Given this list of marker genes Snx18, Rhoa, Spire1, Snx9, Snx33, Spire2, Aurkb, here is a description of the gene set: Mouse Gene Set: GOBP_CLEAVAGE_FURROW_FORMATION Generation of the cleavage furrow, a shallow groove in the cell surface near the old metaphase plate that marks the site of cytokinesis. This process includes the recruitment and localized activation of signals such as RhoA at the site of the future furrow to ensure that furrowing initiates at the correct site in the cell. studied in species Mus musculus